The following is a description of a gene set: studied in species Mus musculus Mouse Gene Set: GOCC_MICROBODY_LUMEN The volume enclosed by the membranes of a microbody., and this is the list of marker genes: Ehhadh, Lonp2, Atm, Gnpat, Acot8, Dao, Cat, Nudt7, Prdx1, Scp2, Agxt, Acaa1a, Ddo, Eci2 (enoyl-Coenzyme A delta isomerase 2), Idh1, Phyh (phytanoyl-CoA hydroxylase), Pomc, Hao1, Acaa1b, Ide, Prdx5, Abcd3, Hspd1, Mvd, Fabp1, Hao2, Acox3, Eci3, Pex5, Pex7, Acox1, Paox, Hsd17b4, Mlycd, Agps, Tysnd1